The following is a description of a gene set: from publication Chen Y, Wang X (PMID 31504780) Genes predicted to be targets of miRBase v22 microRNA hsa-miR-30d-5p in miRDB v6.0 with MirTarget v4 prediction scores > 80 (high confidence targets). species: Homo sapiens Human Gene Set: MIR30D_5P, and this is the list of marker genes: LRRK2, ITGA6, SAMD8, MBTPS2, SHISA3, NR5A2, JPH4, KLF9, ZNF507, FAM133A (NCBI Gene Id 286499), RARRES1, RUNX2, IQCB1, RAB38, IL36RN, SRSF7, ZFY, CCNK, SLC25A34, CYP3A5, MAFG, TLCD4, NECAP1, PCDH17, MAP6, GOLGA6C, UBN2 (ubinuclein 2), EDEM3, MYBL2, ZNF711, DSTYK, TSEN15, CNST, KXD1, STK17B, GFPT2, ATG12, UBAC1, SCYL3, MYO1H, CAMK2N2, PLEKHM3, SACS, DLL4 (delta like canonical Notch ligand 4), PLPP6, DOCK7, CHIC1 (NCBI Gene Id 53344), GPCPD1, RORA, DACT1, PER2, MAB21L1, ZNF704, USP48, C14orf28 (NCBI Gene Id 122525), EFNA3, SCN1A, MIA3, FAM199X, MARK1, PICALM, LYRM7, WWP1, SIX4, KMT2C, B3GNT5, ADAMTS6, OXR1, PPARGC1A, RIMBP2, TRIM13, ARID4A, DOK5, JAKMIP2, STXBP5, RASA1, TP53INP1, RFX6, BNC2, MEOX2, DPYSL2, ANKRD17, TAB3, MYH11, MROH9, MAP3K7 (mitogen-activated protein kinase kinase kinase 7), KRAS, DDAH1, SEPTIN8, CAPZA1, CUL2, SEC24A, ADGRA2, EXOC6, HIC2, SMDT1, CNKSR2, ZFAND5, FBXO45, SEC61A2, CFL2, RHEBL1, NUFIP2, PRPF40A, LIMCH1, ARMH3, PPP1R2, RTKN2, VKORC1L1, ZNF519, RAVER2, SNX10, KLHL28, GPR19, SAMTOR (S-adenosylmethionine sensor upstream of mTORC1), PHF13 (NCBI Gene Id 148479), GPT2, SETD5, ME1, JDP2, CLOCK, PEX5L, ADAM22, KCTD7, LRRC17, PPARGC1B, WDR82, KLF8, BECN1, AVEN, AP4E1, OVOL1, YOD1, RALGDS, SLC4A7, CAND1, UBE2V1, CBLB, ALG10, UBN1, ZNF518A, KCTD8, SLC35B4, MIER3, CCNJL (NCBI Gene Id 79616), MXRA5, MKRN3, MCF2L (NCBI Gene Id 80044), PIGA (phosphatidylinositol glycan anchor biosynthesis class A), CHD1, CALU, FKBP3, GIGYF2, CHMP2B, PI4K2B, TAOK1, TMEFF1, CRACDL, RRAD, EPC2, SDK2, DESI2, TWF1, WIPF1, FAM83F, TOX, FBXO32, PIK3CD, SPOCK3, MLXIP, PON2, NCALD, DPY19L1, FZD3, ERLIN1, SLC38A7, GLDC, MEX3B, LYN, ITPK1, SNX33, SEC22C, SPEN, FNIP2, SH3RF1, ESCO1, GLI2, PGM3, DIPK2A, TTC8, OMG, LMBR1L, WASHC4, ZNF280B, CEP170, DSG2, CCNT2, TDG, KPNA6, P4HA2, PSD3, YPEL2, NHS, MZT1, SKP2, TMEM170B, FAM43A, SNX18, TBL1XR1, RAB8A, KLHL20, EML4, EXTL2, PTPDC1, SETD7, GRM3, LGI1, EIF5A2, STIM2, ZNF644, PGM1, PRG4, DMXL2, PIP4K2A, ATF1, SAMD4A, SP4, EED, RAPGEF2, CYP24A1, OTUD4, LRFN2, PDXDC1, PPP3R1, PROSER1, ZCCHC3, YY2, ADGRL3, SNX16, SAP30BP, COL13A1, NSG1, NFAT5, NCAM1, CMTM4, SHOC2, PRDM13, ZBTB44 (NCBI Gene Id 29068), REEP3, USP37, VIM (vimentin), SCN8A, TRPM7, ZNF22-AS1, CCDC120, RNF220, SLC35A3, BCOR, C4orf19, STX16, MBNL3, PIP4K2B, ZFC3H1, FLVCR2, RAB32, SLC30A4, MEIOB, CTHRC1, LRRC8C, MBOAT1, FRZB (frizzled related protein), CERT1, ASB2, OGA, NEFM, TMEM87A, E2F7, RRAS2, ERICH3, HIVEP1, PAX3, YPEL5, FRMD6, SOCS6, IDH1, ACVR1, SCAF4, PHTF2, TMEM181, FBXL17, SPAST, MPZL3, JADE3, FNDC3A, SLC7A10, PLIN3, GNPDA1, PPP3CA, SCN3A, FAM91A1, ELOVL5, CPNE8, PTGFRN, SRSF10, NUS1, BRD1, SCEL, ZNF286A, NEDD4 (NEDD4 E3 ubiquitin protein ligase), SCARA5, BCL9, TBC1D2B, VAT1, ATP2A2, VAT1L, WIPF3, TASP1, TMEM121B, ALG10B, PLEKHO2, LHX8, BAHD1, CEP41, MARCHF6, RAB23, ACTR3C, NDEL1, EEA1 (early endosome antigen 1), SDAD1, MRPL19, CARF, PFN2, BRWD1, RPRD1A, CCDC97, SLC25A21, COL9A3, PPTC7 (NCBI Gene Id 160760), MARCHF8, CHD7, PAPOLB (NCBI Gene Id 56903), CSNK1A1, RNF157, LHX1 (LIM homeobox 1), DNAJC13, BCL10, MYO5A, MSI2, RAI14, MAML1, C9orf72, PLAGL2, GCLC, SNAI1, CEP350, SCML1, TNIK, ELAVL4, SLCO6A1, MIER2, PDSS1, ANXA2R, SCN9A, VPS26B, CPEB3, CDK12, KCTD16, SLC35C1, GDE1, ST8SIA4, LIN28B, GALNT2, IRF2BP2, MAN1A2, TBC1D15 (NCBI Gene Id 64786), PRUNE2, WDR64, GAREM1, RNF122, CAMK4, GATM, NFATC3, TMOD2, GNAI2, CFAP97, DLG5, FRMPD1, AZIN1, GABRB1, SLC38A2, SLC5A3, TNRC6A, NTNG1, COL25A1, PPP1R12A, GJA1, ARK2C, PCGF5, TENM1, SNX8, TAF4B, LOX, MEX3C, IRF4, HACE1, CNOT9, ZFAND1, EPG5, KIF11, FOXG1, CDC37L1, BNC1, TMEM87B (NCBI Gene Id 84910), ZNF521, DCUN1D3, PDGFRB, PGP, LRRC40, LRRC8D, ACTR1A, ANO4, FAM13A, MAP3K21, SMAP1, CCNA1, TENM3, DOLPP1, TNRC6C, ZXDA, ADRA2A, TENT5A, PPP1R9A, MAST4, ADRA1D, MTDH, CYB561, INO80D, THAP12, LRP6, RUNDC3B, SLC35F1, RAB27B, R3HDM1, RAD23B, IRS1 (insulin receptor substrate 1), ADAMTS3 (ADAM metallopeptidase with thrombospondin type 1 motif 3), SLC25A36 (solute carrier family 25 member 36), FAM229B, TTLL7, DDX59, CBX2, ATP2B1, DCTN4, ARHGAP29, KIF16B, STOX2, FAM110B, ZCCHC2, SH2B3, PPP4R4, RBM12, EEF1A1, ARHGEF6, CBFB, LMBR1, EPB41, GRM5, FIGN, WDR44, SYNGR3, PAXBP1, TSPAN2, ZNF608, DNMT3A, GSKIP, OTUD6B, CARS1, FAM13C, INPP4A, ELOVL2, BRD10, NADK, ESPN, RALGPS1, PTPN13, PIEZO2, KIAA0408, STX2, RAB2A, PAPOLA, AGO3, CPSF6, RGS8, CAMKK2 (calcium/calmodulin dependent protein kinase kinase 2), DLGAP4, ANKRA2, NKX2-2, CALCR, TMCC1 (NCBI Gene Id 23023), STAC, P4HA1, GMNC, CHST2, MTCL2, CHST1, ADGRA3, ZBTB41, ZDHHC17, PRDM1, PAWR, LIFR, KDM3A, PAAF1, NRIP1, PPID, NF1, LRRC8B, DLGAP1, MAPK8, RFX7, ZMYND8, XPO1, LYPLAL1, NFIB, CD2AP, RAPGEF4, SNTB2, KLF10, NEFL, ZEB2, ITGA8, ELAVL2, CSAD, POLR3E, OSTM1, DDIT4, SYPL1, PNKD, CAMK2N1, STK39, GRB10, ZNF382, NUP93, ACTC1, FBXO34, NAV3, UBE2V2, TRAPPC14, HDAC9, YTHDC1, SIX1, CEP15, BDP1, CNOT6, CDCA7, LCORL (ligand dependent nuclear receptor corepressor like), MARCHF4, ATRN, LPGAT1, JOSD1, LCLAT1, ERRFI1, BRAP, HOXA1, GALNT7, ABCC9, ITGB3, ARID1A, MAP3K5, TLL2, CACHD1, IDE, DPY19L3, PDE7A, ARID5B, KIAA1549, CELSR3, GOLGA4, UBE2I, YTHDF3, RTN4R, EDC3, GARRE1, GRIA2, CDH20, KCNA4, CCDC117, MED12L (NCBI Gene Id 57726), CAPN5, IRX4, CERS6, ZBTB6, DNAJC25-GNG10, DGKH, EML1, BNIP3L, TRIO, TULP4, TMEM229A, CCDC6, UBE2J1, SEMA3A, TTBK1, CCDC43, NEUROD1, MFSD6 (NCBI Gene Id 54842), ATG5, PHIP, FGD6, MAST3, ADAM12, ABHD10, SMAD1, PTP4A1, AVL9, GNA13, PPP3CB, ADAMTS9, CCNE2, GMEB2, UNC5C, CSNK1G1, GRIN2A (NCBI Gene Id 2903), NUCKS1, PSMD7, CECR2, CHL1, PPP1R1C, USO1, S100PBP, FOXD1, APBA1, RAB4B (RAB4B, member RAS oncogene family), PNPLA1, DCUN1D1, CSGALNACT1, FBXL20, ARHGAP26, ELMOD2, FAM210B, SOCS1, FAP, STK35, PPP1R18, ATOSA, PRKAA2, IP6K3, A1CF, KSR1, FLVCR1, HIPK2, TUT7, RHD, TNRC6B, ARAF, SLC12A6, RAP1B, NT5E, GALNT1, ROR1, TM4SF1, NLGN1, TFDP1, ASB4, PRICKLE1, NR6A1, RASA2, NHLH2, CADPS, MAP3K2, SLC35F3 (solute carrier family 35 member F3), PCMTD2, TTLL2, NAALADL2, NAA25, SNAI2, RTN4IP1, OSBPL8, MFHAS1, LPP, UGT2A3, TCIM, PHACTR2, PDCD10, SOCS3, RUNX1, UBE3C, MMD, SUV39H2, NRG3, TOGARAM1, KMT2A, PALM2AKAP2, SH3PXD2A, MAT2A, TEPSIN, ADO, LINC03034, BRWD3, YAF2, PDS5B (NCBI Gene Id 80197), ANKHD1, SOX13, STT3B, BCL11B, ZBTB11, ATL2, SEC23A, STAG2, TM4SF20, B4GALT6, SOX9, SEPTIN7 (NCBI Gene Id 989), RARG, CACNB2, NAP1L2, SEMA6B, RAP2C, RASD1, BCL2L11, GNG10, SRGAP3, ZBTB18, RHOB, ATXN1, AFF4, SLC9A8 (solute carrier family 9 member A8), GLCCI1, PRLR, RAPH1, TENT2, WDR7, XPR1, REEP1, IFNAR2 (interferon alpha and beta receptor subunit 2), GOLGA1, NDUFC2, DENND1B, NEURL1B, HYCC2, VOPP1, PLPPR4, NFATC2, HBS1L, TBC1D10B, STRIP1, SSH2, LARGE1, PLA2G12A, HCFC2, KATNBL1, NR4A2, IGF2R (NCBI Gene Id 3482), FHIP2A (FHF complex subunit HOOK interacting protein 2A), ZNRF1, MAP3K13, IL1RAPL2, AFAP1L2, ELL2, GOLGA8A, CRKL, CAMK2D (NCBI Gene Id 817), SLC6A6, RAB15, LIN28A, ERG, PDE4D, ADAM9, EDNRA (endothelin receptor type A), ASB3, MAP4K4, ZPBP2, NAPG, LMLN, ADAM19, PTPN2, HNRNPUL2 (NCBI Gene Id 221092), KLF12, ABL1, SCN2A, TNXB